Given this list of marker genes COX7A2L, DPP7, CCND3, ASXL1, ARSA, UFM1, BLNK, ZZZ3, RLIM, PDE6D, ZNF32, CUEDC2, TSPAN32, C19orf48P (NCBI Gene Id 84798), PLXND1, NAA15, RPS18, CYB5B, BARD1 (BRCA1 associated RING domain 1), ABHD5, UBAC1, SMPDL3A, SPTAN1, ECHS1, ENTPD5, CRYBA1 (NCBI Gene Id 8146), GNG12, SAA1, RPS27L, RAMP1, GABRR2, RAB7A, HMBOX1, MYBPC3 (myosin binding protein C3), EIF1B, SELPLG, P2RY2, RIOK1, KMT2E, RAC3, DALRD3, RSRP1, CCDC12, CRCP, LIN7C, ITM2C, ALDH2, ARRB1, MRFAP1L1, SF3B5, MAP1LC3A, GYG1, KIF1B, HLA-DMA, EIF3D, FH, GDPD3, IDO1, GRK6, SELENBP1, TP53, DUSP2, GALNT11, KIF5C, RPL22L1, S100A4, SLC10A2, ORC4, TIMM10B, NDRG3, EPC1, NUMA1, SLC26A2, ARMC10, KDM5D, ALDOC, PLD4, CH25H, MAP2K1, MRPS11, CCL13, SEC61B, SLC7A1, SIPA1, EPRS1, COQ9, CD8A, RPL18, CDK1, HSD17B11, EIF4B, EPHA7, KIF3A, APCS, RAB5B, ECI2, CCR6, RRN3, FAM120A, TRIM13, TRAK1, AUP1, CLTC, LGALS8, GPX3, DBT, GNAI1, FLCN, EXOC4 (exocyst complex component 4), DR1, TRIM37, SEPHS2, CTDSP2, NID2, GRN, COL13A1, LBR, DCLRE1A, BRWD3, DGUOK, PHB2, TTC27, IARS1, SIRT3, MRPL16, PDCD4, CHP1, CHMP7, ZNF260, PIGX (NCBI Gene Id 54965), CTSA, IL2RA, ATP5F1C (ATP synthase F1 subunit gamma), STK10, XIST, NR3C1, NR1D1, BTF3, RTRAF, POLR1H, NNT, SLC7A7, GRSF1, RMND5A, LSR, EMB, PCBP2, MDM2, ZNF146, TSPAN3, FLOT1, RNF13, BCKDHA, RPL36, RS1, PTDSS2, PLA2G7, NCBP2AS2, ADRB2, SYNGR1, DDX19B, CNR2, HS3ST3A1, LMAN2, KCNJ2, RENBP, FBXW4, PEX11A, RWDD1, EI24, IER2, GGT5, KCNAB2, C5orf34, S1PR4, COPZ1, FERMT3, CBX4, CORT, GAS6, TMX1, HCCS, RGS10, FNTA, RELB, MOB2, RFK, UBALD2, LTC4S, PYCR3, FBXO21, CCR2, SDHC, UROD, TKTL1, BET1, E4F1, FRG1, LIMD2, here is a description of the gene set: Human Gene Set: GSE43955_1H_VS_42H_ACT_CD4_TCELL_WITH_TGFB_IL6_UP Genes up-regulated in CD4 T helper cells Th17 treated with TGFB1 and IL6: 1h versus 42h. from publication Yosef N, Shalek AK, Gaublomme JT, Jin H, Lee Y, Awasthi A, Wu C, Karwacz K, Xiao S, Jorgolli M, Gennert D, Satija R, Shakya A, Lu DY, Trombetta JJ, Pillai MR, Ratcliffe PJ, Coleman ML, Bix M, Tantin D, Park H, Kuchroo VK, Regev A (PMID 23467089) Despite their enormous importance, the molecular circuits that control the differentiation of Th17 cells remain largely unknown. Recent studies have reconstructed regulatory networks in mammalian cells, but have focused on short-term responses and relied on perturbation approaches that cannot be applied to primary T cells. Here, we develop a systematic strategy – combining transcriptional profiling at high temporal resolution, novel computational algorithms, and innovative nanowire-based tools for performing gene perturbations in primary T cells – to derive and experimentally validate a temporal model of the dynamic regulatory network that controls Th17 differentiation. The network is arranged into two self-reinforcing and mutually antagonistic modules that either suppress or promote Th17 differentiation. The two modules contain 12 novel regulators with no previous implication in Th17 differentiation, which may be essential to maintain the appropriate balance of Th17 and other CD4+ T cell subsets. Overall, our study identifies and validates 39 regulatory factors that are embedded within a comprehensive temporal network and identifies novel drug targets and organizational principles for the differentiation of Th17 cells. species: Homo sapiens